Given this list of marker genes LMNA, ZMPSTE24, LBR, IGF2 (insulin like growth factor 2), MKS1, IGF1, DLK1, RTL1, MEG3, HSPG2, SKIC3, PHGDH, CDKN1C, HMGA2, MUSK, PLAG1, here is a description of the gene set: Abnormal placental size A deviation from normal size of the placenta. studied in species Homo sapiens Human Gene Set: HP_ABNORMAL_PLACENTAL_SIZE